Given this list of marker genes SDHA, COX5B, ETFB, MT-ND1, MT-CO3, DLD, NDUFS3, NDUFB6, NDUFB9, NDUFAF1, MT-CO1, NDUFA2, NDUFV1 (NADH:ubiquinone oxidoreductase core subunit V1), UQCC3, COX4I1, NDUFB8, NDUFA7, MT-ND4L, DGUOK, FDX1, NDUFS6, NDUFV2, NDOR1, NDUFA4, UQCRC1, NDUFA11, CYCS, NDUFC2, ISCU, COA6, NDUFB7, NDUFS8, NDUFA12 (NCBI Gene Id 55967), SDHAF2, UQCRHL, GHITM, UQCRC2, COX7A2P2, COX7A2, NDUFA10, UQCRB, COX7B2, COX6A1, SDHB, NDUFA6, NDUFS2, ETFRF1, CYC1, DNAJC15, NDUFA8, NDUFV3, MT-ND4, NDUFS5, SOD2, COX6C, NDUFS4, UQCR11, UQCRH, COQ9, UQCRFS1P1, COX6A2, NDUFA1, UQCR10, CHCHD2, THAP11, NDUFB1, WDR93, COX4I2, IMMP2L, NDUFA9, MTCO2P12, NDUFA5, COX8C, NDUFB2, COX6B1, SDHD, MT-ND2, CCNB1, BID, COX7A1, ENOX2, HCCS, NDUFC2-KCTD14, COX7C, COX7B, PINK1, PLEC, NDUFB3, NDUFS7, MT-ND3, SLC25A51, NDUFAB1, MT-ND5, PPARGC1A, SDHC, MT-CO2, FDX2, ETFA, UQCRFS1, POR, NDUFB10, GBA1, VPS54, SNCA, PDIA5, MT-ND6, NDUFB4, DHRS2, UQCRQ, COX7A2L, CDK1, PUM2, NDUFA3, MT-CYB, SCO2, NDUFB5, ETFDH, MYBBP1A, NDUFC1, COX8A, AIFM2, COX5A, CYB561, MIR210, MTCH2, PARK7, NDUFS1, here is a description of the gene set: studied in species Homo sapiens Human Gene Set: GOBP_ELECTRON_TRANSPORT_CHAIN A process in which a series of electron carriers operate together to transfer electrons from donors to any of several different terminal electron acceptors.